Given this list of marker genes TRHR, IYD, KCNJ10 (NCBI Gene Id 3766), TPO, SLC35A2, DUOX2 (dual oxidase 2), SLC26A4, FOXE1, THRB, PROP1, NKX2-5, HESX1, LHX4, SLC5A5, GLIS3, DUOXA2, TSHR, TG, PAX8, FOXI1, LHX3, POU1F1, NKX2-1, TSHB, here is a description of the gene set: species: Homo sapiens Human Gene Set: HP_ABNORMAL_CIRCULATING_THYROGLOBULIN_CONCENTRATION Abnormal circulating thyroglobulin concentration A deviation from the normal concentration of thyroglobulin, a protein produced in the thyroid gland that acts as a precursor to thyrroid hormones.